Given this list of marker genes MARCHF3, RBMY1F, DAB1, EFCAB11, FGL1, ZNF704, PRNP, ZNF570, ETS1, LRRC42, KIF13A, CRELD1, FGFRL1, CKAP2L, HOXA7, SEC31A (SEC31 homolog A, COPII coat complex component), SLCO5A1, PDZK1, FSTL5, TMED3, AGBL3, MICAL2, DCX, GPBP1L1, SEC23B, GCA, TBC1D22B, C1QTNF7, TMEM33, EFCAB14, CBLN4, SLC66A1LP, ADAM17, KRT6A, TJP2, HOXC8, NME5, LARP4B, TEDDM1, NCAM2, SLC51B, EXTL2, CAT, PDIA4, PTCH1, MORN4, BIVM, ZFPM2, MTMR4, SLC10A7 (NCBI Gene Id 84068), ANGEL2, ACVR2A, TTN, RAB21, VAPA, RAP2C, UBN2, CXADR, UBE4A, DYDC2, CYBRD1, ZNF839, RAD23B, KNL1, FBXO9, LMO7, CLDN8, ZNF347, CYP4V2, CIAO2A (NCBI Gene Id 84191), DNAJC19, RCE1, RPEL1, IDI1, APLP2, GPATCH2L (G-patch domain containing 2 like), FAM133A, SPINK9, BTBD1, SCRN1, RABEP1, SLF2, PHIP, DMAC1, TMEM186, here is a description of the gene set: Genes predicted to be targets of miRBase v22 microRNA hsa-miR-4686 in miRDB v6.0 with MirTarget v4 prediction scores > 80 (high confidence targets). from publication Chen Y, Wang X (PMID 31504780) Human Gene Set: MIR4686 studied in species Homo sapiens